Given this list of marker genes Dlgap1, Mpp2, Dlg3, Shank2, Dlg1, Dlg4, Shank3, Dlg2, Magi2, Ctnnd2, Shank1, here is a description of the gene set: The action of a molecule that contributes to the structural integrity of a postsynaptic density. species: Mus musculus Mouse Gene Set: GOMF_STRUCTURAL_CONSTITUENT_OF_POSTSYNAPTIC_DENSITY